The following is a description of a gene set: Human Gene Set: GOMF_CATALYTIC_ACTIVITY_ACTING_ON_DNA Catalytic activity that acts to modify DNA. studied in species Homo sapiens, and this is the list of marker genes: EXO1, DCLRE1C, DDX3X, BPTF, TOP3A, MYD88, OGG1, POLD3, POLD1, POLG2, ERCC2, TATDN1, PCNA, TOP2B, POLK, ERCC6L, DNASE1L2, HMGA2, PMS2P6, TOP1MT, ATRX, TEN1, SMUG1, MSH2, DNASE1, ENDOG, POLH, SMARCA5, ANKLE1, MAP1S, FAN1, HELB, ALKBH4, PMS2, MSH6, CECR2, BIVM, MEIOB, ENDOV, DHX36, CHTF18, RBBP8, MLH1, APEX2, XRCC3, DDX11, NIPBL, REV3L, UNG, MCM3, POLI, RFC2, DNA2, MAU2, POLE2, DCLRE1B, ERCC6, EXO5, PRIMPOL, ERCC1, DFFA, CRY2, RECQL5, ERCC5, TEFM, CHD6, POLL, WRNIP1, MLH3, MSH3, XRCC2, RUVBL1, DSCC1, RECQL4, MCM7, TOP2A, PGBD5, LIG4, SMARCA1, MCM6, TDP2, PINX1, APLF, CHD3, POLD4, WAPL, EXD2, MRE11, DKC1, MYO18A, HMCES, MPG, PIF1, CHD5, CDK7, APTX, RAD54L, POT1, MGME1, POLM, MCM4, FBH1, BRIP1, PTGES3, INO80, POLA1, MCM5, EME1, ISG20, LIG1, ERCC3, CHD2, NAV2, WRN, SETX, FANCM, ALKBH1 (alkB homolog 1, histone H2A dioxygenase), TREX2, TET2, RTEL1 (regulator of telomere elongation helicase 1), DFFB, XRCC6, TERF2, POLB, MCM8, RAD51D (NCBI Gene Id 5892), PMS2P3, SUPV3L1, RECQL, SETMAR, CRY1, BLM, RAD9A, THAP9, HMGA1, MUTYH, TDG, ZGRF1, DDX11L8, RSF1, SMARCA4, PLD4, N4BP2, FEN1, ASCC3, PLD3, DHX9, POLE4, DDX1, HLTF, CHD4, MCM2, RAD17, DCLRE1A, RAD1, SLX1A, REV1, MBD4, RAD54L2, RFC3, POLG (DNA polymerase gamma, catalytic subunit), ZRANB3, DNMT3A, MGMT, METTL4, SLX1B, DHX30, MCRS1, DNMT3B, PMS2P1, DMC1, REXO2, TET1, DYNLL1, POLN (NCBI Gene Id 353497), XRCC1, RPS3, DDX12P, HFM1, ALKBH2, RAD51B, NEIL3, CHTF8, CHD8, CHRAC1, GEN1, POLE, HELQ, UPF1, NEIL2, DNASE1L1, DNASE2, LIG3, RAD51, DNMT1, SPO11, TERT, TOP1, FTO, TEP1, ALKBH3, TDP1 (tyrosyl-DNA phosphodiesterase 1), NEIL1, RBBP4, PMS2P5, CHD1, G3BP1, ACD, EXOG, MSH5, ATAD5, RAD50, TOP3B, MCM9, SMARCA2, AEN, CHD7, CHD1L, DNASE2B, TET3, RAG1 (NCBI Gene Id 5896), IGHMBP2, RFC5, SMARCAD1, ERCC4 (NCBI Gene Id 7509), RFC4, RUVBL2, APEX1, SMARCAL1, DNTT, POLQ, TREX1, RFC1, RAD54B, MSH4, NME1, DICER1, TWNK, TTF2, XRCC5, MUS81, POLE3, NTHL1, EME2, BTAF1, TERC, TERF1, DNASE1L3 (deoxyribonuclease 1L3), C1QBP, PMS1, RAD51C, TP53, N6AMT1, ASTE1 (NCBI Gene Id 28990)